Given this list of marker genes SF1, NUS1, CREB3L1, PRKCB (NCBI Gene Id 5579), FZD1, TNRC6B, INPPL1, AGO2, ATXN2L, EPB41L5, SLC6A9, UBAP2, ST20-AS1, here is a description of the gene set: Genes having at least one occurence of the motif TCCGTCC in their 3' untranslated region. The motif represents putative target (that is, seed match) of human mature miRNA hsa-miR-184 (v7.1 miRBase). species: Homo sapiens Human Gene Set: TCCGTCC_MIR184